Given this list of marker genes Ppp1r9a, Arhgap33, Opa1, Stau2, Baiap2, Ephb3, Pafah1b1, Ube3a, Efna1, Marcks, Ngef, Adam10, Hdac6, Reln, Caprin2, Lzts3, Dtnbp1, Dbn1, Epha4, Dnm3, Pdlim5, Pten, Cfl1, Ppfia2, Nlgn1, Cdk5, Myo5b, Ephb2, Dnm1l, Dhx36, Cdk5r1, Camk2b, Dlg4, Pak3, Abi3bp, Sipa1l1, Lrp8, Cask, Cux2, Eef2k, Wnt7a, Tiam1, Septin7, Nlgn3, Ephb1, Xlr3b, Cdc42, Ctnnd2, Il1rapl1, Kalrn, Arhgap44, Shank3, Prmt3, Dvl1, Actr2, Bhlhb9, Abi2, Arc, Shank1, Epha5, Zdhhc15, Caprin1, Mfn1, Afdn, Wasl, Abi3, Zfp365, Itpka, Dip2a, Lrrk2, Actr3, Dock10, Ptprd, Tanc2, Dbnl, Slc30a1, Mfn2, Srcin1, Kif1a, here is a description of the gene set: studied in species Mus musculus The process in which the anatomical structures of a dendritic spine are generated and organized. A dendritic spine is a protrusion from a dendrite and a specialized subcellular compartment involved in synaptic transmission. Mouse Gene Set: GOBP_DENDRITIC_SPINE_MORPHOGENESIS